The following is a description of a gene set: from publication Konuma T, Nakamura S, Miyagi S, Negishi M, Chiba T, Oguro H, Yuan J, Mochizuki-Kashio M, Ichikawa H, Miyoshi H, Vidal M, Iwama A (PMID 21540074) Each fraction of mouse hematopoietic cells was purified by cell sorting from bone marrow of 8-week-old C57BL/6 mice, and its gene expression was analyzed. Genes up-regulated in comparison of CD4 T cells versus erythroblasts. Human Gene Set: GSE27786_CD4_TCELL_VS_ERYTHTROBLAST_UP studied in species Homo sapiens, and this is the list of marker genes: CEP55, KCNQ1OT1, PRMT9, PPIL3, RER1, NISCH, RAD1, STARD3, LRRC1, UBR5, FAM98B, SGCB, KPNA4, SLC35A3, AP3M2, LYAR, NDUFS7, PRPF6, LRCH3, TLE5, ADO, TBC1D14, ZFP36, DPP3, PRKAR2A, GMPR2, POLR1C, CHD7, GLRX3, IGFLR1, RP9, CYP2D6, TRIM14, DYNLT3, POMP, BBS12, API5, TIMP2, EMC2, BOP1, EFL1, LCLAT1, LXN, GLB1, PLSCR1, DICER1, RWDD4, LSM14B, AGFG1, RAI1, C12orf43, PPCDC, EIF3K, MTIF3, YIPF3, TBL1X (transducin beta like 1 X-linked), NCF4, TNKS2, CLUAP1, TMEM161B, RMND5B, APPL1, MANBA, DDX28 (DEAD-box helicase 28), ZNF707, JAK1, PREX1, SIRT7, CD200R1, POGLUT2, PLCL1, PACC1, TAF1C, RFX3, CDK13, ZC3H13, TRMT10B, TUFM (NCBI Gene Id 7284), ANKRD37, BCLAF1, FAM168A, EXOC1, ARID4A, GPN2, MFAP1, EIF2B1, SOCS7, TNFAIP8L1 (TNF alpha induced protein 8 like 1), NAXE, IFT27, SIRT2, DNMBP, PPP1R21, CAPNS1, IRF2, FMNL3, MYO5A, MFGE8, GOLGA4, GSTO1, FUCA1, PDE4B, CSNK1E, MCCC2, UPF3A, PRRC1, PRKCD, AQR, TCN2, MNT, ITPRIPL2, PARG, CELSR1, DHX33, ABL2, TGIF1, CHM, SLC30A6, ZNRF1, CATSPERD, PTPN21, SF3A3, DNAH8, CRTC3, DNAJA1 (DnaJ heat shock protein family (Hsp40) member A1), ATP6V1H, MRPS16, ZMYM4, NDUFA13, TNFAIP8, ZCCHC2, SLC37A4, PADI4, RSF1, PSEN1 (presenilin 1), MIA3, HMGN5, TRPM7, ZNF512B, ACP3, DBNL, SURF1, NAB1, STYX (serine/threonine/tyrosine interacting protein), PPHLN1, CCDC9, TRMT61A, NTHL1, PPIG, RLF, FBXO25, PLPP6, ABHD11, PHF6, ARID3B, BRWD1, PRXL2B, TRIP4, C22orf39, JAGN1, PPP4R2, CSNK1D, FHOD1, UBE2L3, RORA, SLA2, MAP3K3, NDUFA6, ARPC5L, NT5C3B, KMT2D, PHKG2, EMC1, CGAS, GLOD4, SLC38A10, PHTF1, NRDE2, POGLUT3, LMNTD2, CDK9, RGS1, RBFA, TMEM70, C9orf78, FHIP2A, CD44, PARP1, SEPHS2 (NCBI Gene Id 339090), IER3IP1, WDFY2, IRAG2, MMS19, IKZF1, PGLYRP1 (peptidoglycan recognition protein 1), YTHDF2, NDRG3, AGPAT5, TTC33, CCDC115